Given this list of marker genes RAB11A, NETO1, KCNJ10 (potassium inwardly rectifying channel subfamily J member 10), NPTN, FXR2, RAB8A, EPHB2, SYNGR1, KIT, SYP, APP, GRM5, DLG4, NEURL1, SHANK3 (NCBI Gene Id 85358), HRAS, SYNGAP1, RAB5A, GRIK2, FXR1, NF1, DRD2, FMR1, CAMK2B, KRAS, SNCA, here is a description of the gene set: A process that modulates long-term neuronal synaptic plasticity, the ability of neuronal synapses to change long-term as circumstances require. Long-term neuronal synaptic plasticity generally involves increase or decrease in actual synapse numbers. species: Homo sapiens Human Gene Set: GOBP_REGULATION_OF_LONG_TERM_NEURONAL_SYNAPTIC_PLASTICITY